The following is a description of a gene set: The region of a condensed chromosome that includes the centromere and associated proteins, including the kinetochore. In monocentric chromosomes, this region corresponds to a single area of the chromosome, whereas in holocentric chromosomes, it is evenly distributed along the chromosome. species: Homo sapiens Human Gene Set: GOCC_CONDENSED_CHROMOSOME_CENTROMERIC_REGION, and this is the list of marker genes: RASSF2, MAD2L1, H3-3A, MIS12, MAD1L1, SKA1, SKA2, SYCP2L, NSL1, CDC20, ZWINT, FIRRM, CDT1, PSEN2, TP53BP1, CENPU, AURKA, XPO1 (exportin 1), KAT8, BRD7, CHMP1A, BUB1, HNRNPU, NCAPD3, SEC13, CENPF, SEH1L, KIF22, DYNLT3 (NCBI Gene Id 6990), SIN3A, CHMP1B, SPOUT1, KAT2B, CENPS, SMARCE1, DYNC1LI1, NCAPD2, PLK5, SUMO3, CHMP4C, CENPA, DYNC1I1, CENPW, NUP37, CSNK1A1, NUP160, AURKC, KMT5B, NUP85, HSF1, CENPV, SEPTIN6, NDE1, CENPC, APC, ZNF276, BUB1B, CENPE, SEPTIN7, ACTL6B, TTK, CHMP6, FBXO28, CKAP5, CENPT, KNL1, NUP98, PAFAH1B1, DCTN4, KIF18A, SPC24, CENPI, SUGT1, CHAMP1, PRP4K, PMF1, ANAPC16, ORC2, DCTN1, SPDL1, SEPTIN2, CENPP, ACTB, KNSTRN, NEK2 (NIMA related kinase 2), ERCC6L, CHMP4BP1, CENPN, NUDCD2, BUB3 (NCBI Gene Id 9184), KIF2C, SMC1A, PSEN1, AHCTF1, RANGAP1, CENPB, NUP43, MEAF6, KAT5, ACTL6A, NDC80, DCTN6, ATRX, REC8, CHMP3, KNTC1, SMARCD1, SYCP2, SGO2, PHF10 (PHD finger protein 10), PPP1CC, KIF2B, KMT5C, SPAG5, DCTN3, CFDP1, SMARCD2 (SWI/SNF related, matrix associated, actin dependent regulator of chromatin, subfamily d, member 2), NDEL1, NCAPG, INCENP, SKA3, SMARCB1, GPATCH11, LRWD1, SS18L1 (NCBI Gene Id 26039), SMARCC2, CENPX, ARID2, NUP133, NUF2, GTF2B, CEBPB, DYNC1LI2, CHMP4B, MEIKIN, BIRC5, CENPO, SMARCA4, NUP107, SMARCC1, CLIP1, PLK3, CENPK, MTCL1, CHMP4A, CLASP1, SGO1, DYNLL1, PHF6, SPC25, CENPQ, PBRM1, PLK1, ITGB3BP, ZW10, CBX3, CHMP2B, TEX14, PHF2, DCTN5, PLK2, CHMP2A, CCNB1, PINX1 (NCBI Gene Id 91819), DCTN2, CHMP5, BOD1L2, ZNF207, FBXW11, CENPL, CBX5, AURKB, MTBP, TRAPPC12, DSN1, PPP1R12A, CLASP2, KANSL1, CHMP7, H3-3B, BOD1 (NCBI Gene Id 91272), CENPH, CENPM, HJURP, TPR, ZWILCH